The following is a description of a gene set: The evagination of a Golgi membrane, resulting in formation of a COPI-coated vesicle. Human Gene Set: GOBP_COPI_COATED_VESICLE_BUDDING species: Homo sapiens, and this is the list of marker genes: TMED2, GBF1, TMED10, TMED9, ARFGAP2, ARFGAP3